Given this list of marker genes Dhodh, Sdhd, Ppox, Sdhb, Sdha, here is a description of the gene set: Mouse Gene Set: GOMF_OXIDOREDUCTASE_ACTIVITY_ACTING_ON_THE_CH_CH_GROUP_OF_DONORS_QUINONE_OR_RELATED_COMPOUND_AS_ACCEPTOR species: Mus musculus Catalysis of an oxidation-reduction (redox) reaction in which a CH-CH group acts as a hydrogen or electron donor and reduces a quinone or related compound.